Given this list of marker genes C1QL3, NOL11, CCT2, ATP5F1A, HSD17B10, ITGAX, THOC7 (NCBI Gene Id 80145), DCXR, XRCC6, BCLAF1, TOMM7, SH3TC1, WDR46, EEFSEC, KLRC3, CD80, IMPA1, NDUFA7, HDDC2, TOR3A, PPAN, PRMT2, MCOLN3 (NCBI Gene Id 55283), TMEM168, ZNF362, DBNL, HINT3, DUSP1, NSG2 (neuronal vesicle trafficking associated 2), SIDT1, RAP2C, DKK1, PRPF38A (pre-mRNA processing factor 38A), MED1, OLFML2B, CHURC1, ID3, PCSK1, PICK1, MTA1, SLFN12L, MAPK1, TMEM126A, WDR90, PTPMT1, RBM17, DR1, EPM2AIP1, CACNA1S, GGT1, PABPC4, SHMT1, RNF7, TBXT, SLAIN1, EPCAM, PARL (NCBI Gene Id 55486), NEFM, MYF6, HGSNAT, MAN2C1, TBRG4, ERI2 (NCBI Gene Id 730570), ZNF219, RABL6, TPRKB, VRK2, CSNK1A1, TAPBP, MLF2, MRPS6, HNRNPDL, GRK5, SPOP (speckle type BTB/POZ protein), AP4B1, NUP160, SOX4, DDIT4L, ATXN1, IMMP2L, NEK4 (NCBI Gene Id 8380), ATP8A1, EBAG9, TP53BP1, PXMP2, CUTC, PSRC1, RBM28, ECRG4, IREB2, FOXP1, URI1, MAPRE2, CHST15, CDC26, PLPBP, DLK2, PPP4R2, IFI27L2, LACTB, OXLD1, CYBA, LARP1, ZNF703, HOXB1, PRXL2A, IGHM, RPS19, SLC37A1, MYH2, ZFHX4, ECI1, PTS, AEN, MRPL44, KPNA6 (karyopherin subunit alpha 6), EXOC6, C11orf58, SLC25A17, CD320, ENTPD7, COX6C, MAPK8, SFRP5, SMYD1, EPS15, PPP2R3A, RNF135, VWA7, SIAH2, TMA16, SYNJ2, MTERF4, NUDT19, YBX1, XCL1 (X-C motif chemokine ligand 1), STARD4, NUDT5, SDF4, PYROXD1, FHL2, PRMT7, PSME1, EXOSC10, CFLAR, H3C7, BDH1, TOX (thymocyte selection associated high mobility group box), CALB2, EN1, PSMB6, TAMALIN, TIMM50, PLAGL1, EIF4E, RTL6, NAB2, AFMID, KRBA1, TMEM223, FAM81A, SPTSSB, SLC25A3, RASSF3, TM2D3, DNAJA1, TBX3, DGLUCY, CCDC86, USP25, ERGIC1, C5orf22, NMNAT1, ZFAND5, FAS, PLAAT3, PTPN9, PSMB8, ST6GALNAC4, CPSF3, EIF3I, INTS14, KCNN4, ATG3, STK39, HADHA, MCOLN2 (mucolipin TRP cation channel 2), CEP15, NUP85, DNAJC12, TBCE, GNE, KMT2A, CILK1, RAB3IP (RAB3A interacting protein), IFNG, ANAPC13, RAD51, here is a description of the gene set: Genes up-regulated in IKZF1 knockout: hematopoietic stem cells versus lymphoid-primed multipotent progenitors. from publication Ng SY, Yoshida T, Zhang J, Georgopoulos K (PMID 19345118) Human Gene Set: GSE15330_HSC_VS_LYMPHOID_PRIMED_MULTIPOTENT_PROGENITOR_IKAROS_KO_UP species: Homo sapiens Regulation of lineage potential and transcriptional priming by Ikaros. New insight is provided into a bivalent regulation of lineage priming in the HSC and its lympho-myeloid restricted progeny the LMPP by the lymphoid lineage-determining factor Ikaros Whereas Ikaros is responsible for the activation of a cascade of lymphoid expression programs and for the establishment of lymphoid potential from the HSC to the LMPP it is also responsible for the repression of stem cell and erythroid genetic programs that are incompatible with further lineage restrictions emanating from the LMPP